Given this list of marker genes SLAMF1, ROCK2, SLC5A3, GPR89A, G3BP1, PATZ1, NFYA, DACH1, CXCR4, CDK8, SLC39A12, PRKAR2B, TBC1D14, ST8SIA3, CLK1, SPTY2D1, INSIG2, JRKL, WASL, MBNL1, MYLIP, FKTN, SMARCAD1, RPP14, RAB10, HOXA9, BCL10, ARHGAP20, IRF2, DIO3, ANKS1A, MARCHF1 (membrane associated ring-CH-type finger 1), YAP1, CSF2RB, AMPH, APPL1, POU3F3, YTHDF1, MYL12A, SRSF1, ETFBKMT, FRS2, SS18, USP44, FKBP15, DCUN1D5, DKK2, EYA1, NAA25, FRAS1, RALGPS1, RCOR1, ATF2, DBNDD2, GHR, CAMTA1, PHACTR2, DGKB, PTGES, TCF7L2, VCF1, ING1, ZMYM2, SERAC1, UBE2K, DYRK2, CACNG2, USP9X, DYRK4, ANKRD20A3P, TGIF1, DCUN1D1, TXLNG, ESRRG, VIPAS39, BNIP3, PPP1R2, PDE3A, RXRB, GPSM2, TTC17, CNTNAP2, SPRY3, here is a description of the gene set: Human Gene Set: MIR622 from publication Chen Y, Wang X (PMID 31504780) Genes predicted to be targets of miRBase v22 microRNA hsa-miR-622 in miRDB v6.0 with MirTarget v4 prediction scores > 80 (high confidence targets). species: Homo sapiens